The following is a description of a gene set: studied in species Mus musculus Any process that activates, maintains or increases the frequency, rate or extent of the change in the membrane potential of the mitochondria from negative to positive. Mouse Gene Set: GOBP_POSITIVE_REGULATION_OF_MITOCHONDRIAL_DEPOLARIZATION, and this is the list of marker genes: Cck, Oga, Rack1, P2rx7, Myoc, Dcn, Tspo, Parp1, Adcy10, Alox12, Kdr, Mllt11